Given this list of marker genes PLCG1, FRS2, HRAS, GAB1, PIK3R1, FGFR4, NRAS, GRB2, SOS1, KRAS, PIK3CA, here is a description of the gene set: FGFR4 is perhaps the least well studied of the FGF receptors, and unlike the case for the other FGFR genes, mutations in FGFR4 are not known to be associated with any developmental disorders. Recently, however, somatically arising mutations in the FGFR4 coding sequence have begun to be identified in some cancers. 8% of rhabdomyosarcomas have activating mutations in the kinase domain of FGFR4. Two of these mutations - N535K (paralogous to the FGFR2 N550K allele found in endometrial cancers) and V550E - have been shown to support the oncogenic transformation of NIH 3T3 cells. An FGFR4 Y367C mutation has also been identified in breast cancers; mutations of paralogous residues in FGFR2 and FGFR3 are associated with both skeletal dysplasias and the development of diverse cancers.<br><br><br>Finally, a SNP at position 388 of FGFR4 is associated with aggressive disease development. Expression of the G388R allele in breast, colorectal and prostate cancers is correlated with rapid progression times and increased rates of recurrence and metastasis. Reactome Pathway: Signaling by FGFR4 in disease part of: Signaling by FGFR in disease studied in species Homo sapiens